Given this list of marker genes TRPC5, CRIPT, CLDN11, AJUBA, KDM5D, TMT1B, SHISA6, SMARCC2, MTHFD2, POU2F2, AGGF1, CCL22, SCN2B, INO80D, UBIAD1, WBP2NL, GRIK3, STC1, EIF5A, GATAD2B, FOXP4, DACT3, TOB2, S1PR2, SLC29A1, ALDH3A2, COL5A3, UBTF, SLC25A13, RIMBP2, FAM168A, C1QC, MTCL2, NOVA1, RBFOX2, KCNC1, DNAL1, LINC03040, BCAS1, LDB1, GPD1, ANKRD26, MARCKS, TRA2B, THRSP, NEUROD2, KALRN, IRAG2, PIP4K2B, ZNRF1, SYNGAP1, MAGI2, PCDHB4, PRR14L, HNRNPA3, P2RY2, NGFR, ASH2L, PPP2R5D, HSPA9, ARHGAP26, MAFF, LARP1, RAB11B, HNRNPC, MPV17L, SMDT1, VCAN, TEF, CSNK1A1L, RNASEH2C, PDZD7, RBM14, BRME1, DLK1, BARHL1, CCDC97, LRRC59, CD1E, SCN4A (NCBI Gene Id 6329), CSNK2A1, SPDYA, HHLA2, ARL14EP, HS3ST3B1, GSTM2, MSN, MARK2, SRCIN1, TRNT1, RD3, PA2G4, SPRYD3, SLC6A17, CSNK1A1, NYAP1, SHANK1, ARL4D, DAGLA, ATP2B4, ZBTB18, DCAF12, STXBP1, SPINDOC, TXNIP, RIMS4, DNAAF11, ANKRD52, ARHGAP39, ELK1, SLC7A6, ADRA2B, BRPF3, APOA5 (NCBI Gene Id 93561), SLC25A37, DAAM2, TTC7B, POU3F2, STRN, APLNR (NCBI Gene Id 187), WNK3 (NCBI Gene Id 65267), SNX9, OSBP2, ENO2, CDC20B, KCNH4, MGRN1, CPSF7, RAB5B, PPHLN1, RETREG3, VAT1, TMOD2, SPTB, TNRC6B, EHMT2, NACC1, NFASC, MIEN1 (NCBI Gene Id 84299), PRKACA, NFIC, PRRT2, TCP10L2, MLXIP, BNC2, PRLHR, PTPRH, PELO, ASIC1, SIRPB2, SLC16A2, GABPB1, SFTPB, SCN4B, TLE3, ATAD3C, STMND1, IQSEC3, GPSM1, UNC119, CHAD, NOVA2, MEF2D, MRO, SART3, CELF3, RIMS3, ATP8A2, TRIM66, SETD5, SYVN1, ZNF609, TTC9, ZFYVE28, TFAP2B, here is a description of the gene set: from publication Chen Y, Wang X (PMID 31504780) studied in species Homo sapiens Human Gene Set: MIR3175 Genes predicted to be targets of miRBase v22 microRNA hsa-miR-3175 in miRDB v6.0 with MirTarget v4 prediction scores > 80 (high confidence targets).